Given this list of marker genes FAM111A, GALE, PARVG, COMMD5, FLOT1, PCYT1A, CASP4, TEDC1, DCUN1D1, AIP, RPAP2, SNX2, ZFP62, GRIK4, BET1, MBD1, PRKCSH, CCNC, APOBR, IMMP2L, DHDH, EMC2, NUPR1, MAPK13, TNFRSF1B, ACTG1, CUZD1, MRPL1, PLD4, RBM8A, AKIP1, MRPL34, PLXNB3, PDZD11, RAB5A, GMPR2, LMAN1, NSMCE2, RUVBL2, LUZP1, AIFM1, APIP, PRDM5, CACNB4, ITGB3BP, COX17, YME1L1, CST3, PSMA1, PGRMC2, ATG4B, YAF2, RILPL1, PPIA, CEP83-DT, NR1H2, TBPL1, DGCR6, SLC24A3, GADD45B, TNP1, ULK2, CUL4A, TUBG1 (tubulin gamma 1), OGFRL1, WDR45, TTC9C, PPP1R15B, POLR3C, VAMP4, NDUFA9, FDXR, FOCAD, ECI1, PXMP2, USP47, OTOS, TMEM143, BIK, ERN1, HJURP (Holliday junction recognition protein), C19orf25, ANAPC2, DNAJC3, DBR1, ARB2A, PBDC1, ANO10, MBOAT1, LYAR, SUB1, FAM216A, SRSF10, SDR39U1, BHLHE40, POLR2F, SMYD3, ANTKMT, CCT8, BRI3, HUS1, KIF18A (NCBI Gene Id 81930), INTS8, ATRAID, NSMF, WDR62, ATP5MK, MRPS15, BORCS7, GRAMD1B, LRRC59, IRS2, SEPTIN9 (NCBI Gene Id 8162), AEBP2, MRPL51, AKR1B15, TRIM46, LONP1, HCLS1, BCAS3, CNIH1, PTTG1IP, TXNDC17 (NCBI Gene Id 84817), CNOT11, RETSAT, SLC36A4, WARS1, RWDD1, ZC2HC1A, B2M, ZYX, SPIDR, GINS4, DPP7, CSNK2B, OSBPL5, WBP11 (WW domain binding protein 11), COPS5, TRIM45, LARP1, WDR91, ZBTB7A, HELB, HSD17B12, PITPNB, RRS1, ARPC1A, YIPF1, ABCA8, NDUFS5, ARHGEF10, C11orf54, RSL24D1, MRPL48, TST, USP5, NAA38, AARSD1, NDE1, BAX, RHEBL1, SPRY2, PTPN4, CSF2RA, CISD3, MACIR, PCNA, HARBI1, CAT, MYO15B, METTL5, EID2, NDUFA13, HDHD3, C6orf118, SSU72, UNC93B1, MPV17L2 (NCBI Gene Id 84769), ADARB1, MIB1, MYO1E, GATAD1, RAD51D, SGCB, CFAP68, KIFAP3, HRH2, BLOC1S5, NKAIN2, FAM174A, PSMB4, TENT4A, MPHOSPH6 (NCBI Gene Id 10200), SERPINF1, PSMB2, TMEM241, DRC3, UCHL1, FAM204A, SNRPA1, here is a description of the gene set: Genes up-regulated in comparison of Th1 cells versus naive CD4 T cells. studied in species Homo sapiens Human Gene Set: GSE14308_TH1_VS_NAIVE_CD4_TCELL_UP from publication Wei G, Wei L, Zhu J, Zang C, Hu-Li J, Yao Z, Cui K, Kanno Y, Roh TY, Watford WT, Schones DE, Peng W, Sun HW, Paul WE, O'Shea JJ, Zhao K (PMID 19144320) Multipotential naïve CD4+ T cells differentiate into distinct lineages including T helper 1 (Th1), Th2, Th17, and inducible T regulatory (iTreg) cells. The remarkable diversity of CD4+ T cells begs the question whether the observed changes reflect terminal differentiation with heritable epigenetic modifications or plasticity in T cell responses. We generated genome-wide histone H3 lysine 4 (H3K4) and lysine 27 (H3K27) trimethylation maps in naïve, Th1, Th2, Th17, iTreg, and natural (n)Treg cells. We found that although modifications of signature cytokine genes (Ifng, Il4, and Il17) partially conform to the expectation of lineage commitment, critical transcription factors such as Tbx21 exhibit a broad spectrum of epigenetic states, consistent with our demonstration of T-bet and IFN-gamma induction in nTreg cells. Our data suggest an epigenetic mechanism underlying the specificity and plasticity of effector and regulatory T cells and also provide a framework for understanding complexity of CD4+ T helper cell differentiation.